The following is a description of a gene set: Mouse Gene Set: GOMF_FRUCTOSE_6_PHOSPHATE_BINDING species: Mus musculus Binding to fructose 6-phosphate., and this is the list of marker genes: Pfkp (NCBI Gene Id 80680), Gckr, Pfkl, Pfkm, Pfkfb1